The following is a description of a gene set: Any process that activates or increases the frequency, rate or extent of hepatic stellate cell activation. Mouse Gene Set: GOBP_POSITIVE_REGULATION_OF_HEPATIC_STELLATE_CELL_ACTIVATION species: Mus musculus, and this is the list of marker genes: Fgfr1, Pdgfrb, Pdgfb, Myb, Rps6ka1, Smo, Dgat1, Ddr2, Lep, Acta2